Given this list of marker genes Cldn1, Rock2, Rps6, Fzd5, Cldn3 (claudin 3), Rac1, Cldn5, Tjp1, Dsg3, Epha2, F11r, Tnf, Nphp4, Rock1, Il17a, Pkp2 (NCBI Gene Id 71741), Snai2, Rps6-ps4, Prkch, Nedd4l, Gdf2, Acvrl1, Prkaca, Myo1c, Snai1, Gpbar1, Nphp1, Ikbkb, Gja1 (NCBI Gene Id 14609), here is a description of the gene set: species: Mus musculus Mouse Gene Set: GOBP_REGULATION_OF_BICELLULAR_TIGHT_JUNCTION_ASSEMBLY Any process that modulates the frequency, rate or extent of tight junction assembly.